The following is a description of a gene set: species: Homo sapiens Human Gene Set: GSE24142_EARLY_THYMIC_PROGENITOR_VS_DN2_THYMOCYTE_ADULT_UP Development of T-cells provides a unique opportunity to study cell-fate determination due to the accessability and the well defined stages of developmental stages. In order to understand the genetic programs underlying fetal and adult T‑cell fate specification we subjected highly purified fetal and adult T-cell progenitor populations to a genome‑wide transcriptional analysis. The aim was to identify molecular elements that govern T-cell fate specification as a whole but ultimately to isolate elements that were specific for a given population in a specific developmental window. from publication Belyaev NN, Biró J, Athanasakis D, Fernandez-Reyes D, Potocnik AJ (PMID 22581009) Genes up-regulated in comparison of adult thymic progenitors versus adult DN2 thymocytes., and this is the list of marker genes: AKAP9, FRMD4B, STX3, MYLK, RGS1, HLA-DRB1 (NCBI Gene Id 730415), CTSS, PLBD1, FAM91A1, NEK6, ZBTB14, TMEM51, SESN3, SLC25A53, DOCK7, SLC29A3, OLIG3, LPIN1, ZFHX3, CCND1, TGFBR2, FHOD3, PARP3 (NCBI Gene Id 25908), ZNF467, TMPRSS3, YTHDC1, GRAMD1A, RAB31, CTBP2, VSIR, MFSD6, ATP8A2, BCL11A, ARHGAP6, MEIS1, TRIT1, DNAJB9, ADGRG3 (adhesion G protein-coupled receptor G3), TTPA, GOLM1, TLR7, CREBZF, N4BP2L1, FLT3, RSRP1, RETREG1, PRDM5, IL18R1, PTPRE (NCBI Gene Id 5791), FCGR2A, CAMK1D, IFI44, ICE1, TAL1, IL18, ROBO1, ZMAT3, MAP4K5, APOBR, ZNF436, CD33, FES, S100A4, RNF149, PIGP, ITIH5, ADAM17 (ADAM metallopeptidase domain 17), RHOQ, ECEL1, ZNF503, CD300A (CD300a molecule), MMP2, CYP4V2, SHISA2, HCK, LPL, ACVR2A, TENT5C, ID2 (inhibitor of DNA binding 2), BCL6, NIBAN2, CD34, CSF1R, MYLIP, RGS8, GEM, PRTN3, B4GALT6, LIG3, LTBP3, LRRK1, HOXA9, RUFY1, TCF7L2, IL1R2, CDH17, WDFY2, HHEX, CD86, CD300LF, SLC25A36, ST3GAL2 (NCBI Gene Id 729518), IL18RAP, EBI3, ITSN1, IL15, VAV3, PLXNC1, FGD2, SLCO3A1, ZNF623, BFAR, IQGAP2, PEAR1, CD27, JARID2, SPAG1, MYCN, CLEC4E, FFAR2, TYROBP, ZBTB20, LYN, DENND5A, SCAF11, DDHD2, PARP6, CA2, TCEAL1, GCNT2, PTPN12, MEF2C, TACR2, RGS18, TSC22D1 (TSC22 domain family member 1), PARP8, TIRAP, DDX4, ECE1, KLRD1 (NCBI Gene Id 92677), PPP3CA, PKD2, VILL, SOX4, IL1R1, ABCA1, GP9, CD81, PTGER2, VCL, MYADM, C21orf91, PLEK, IL10RB, BBX, NCF1, DZIP1, DGLUCY, SLC25A45, GLIPR1, APPL2, GDPD5, SPINT1, HNF4A, TEF, HMGA2, ODR4, RPGRIP1, ACSL1, ANXA1, SASH1 (SAM and SH3 domain containing 1), LGALSL, ITGB2, ST6GAL1, HOXA11-AS, CASD1 (NCBI Gene Id 85885), HADH, IRF6, CTNND2, INTS6L, NUCB2, TBK1, SPOP, CD52, GPRC5B, RASA2, RFLNB, ANTXR2, IRF8, EID1 (EP300 interacting inhibitor of differentiation 1), EVI2B, P2RY14, HLA-DQA1, ADGRL4, SPECC1, TRIO, LBP, PRKCE, FASLG, LMO2